Given this list of marker genes Apoc3, Mia3, Unc119, Apob, Cubn, Apoc2l, Msr1, Lrp2 (NCBI Gene Id 99378), Cd36, Zdhhc3, Surf4, Pgrmc1, Apoc2, Vmp1, Zdhhc17, Unc119b, Apoe, Lsr, Mttp, Sar1b, Pparg, Apobec1, Tmem97, Mia2, here is a description of the gene set: Any process in which a lipoprotein is transported to, or maintained in, a specific location. Mouse Gene Set: GOBP_LIPOPROTEIN_LOCALIZATION studied in species Mus musculus